The following is a description of a gene set: Genes up-regulated in T98G cells (glioblastoma) by TNC. Human Gene Set: RUIZ_TNC_TARGETS_UP species: Homo sapiens Tenascin-C is an adhesion-modulating extracellular matrix molecule that is highly expressed in tumor stroma and stimulates tumor cell proliferation. Adhesion of T98G glioblastoma cells to a fibronectin substratum is inhibited by tenascin-C. To address the mechanism of action, we performed a RNA expression analysis of T89G cells grown in the presence or absence of tenascin-C and found that tenascin-C down-regulates tropomyosin-1. Upon overexpression of tropomyosin-1, cell spreading on a fibronectin/tenascin-C substratum was restored, indicating that tenascin-C destabilizes actin stress fibers through down-regulation of tropomyosin-1. Tenascin-C also increased the expression of the endothelin receptor type A and stimulated the corresponding mitogen-activated protein kinase signaling pathway, which triggers extracellular signal-regulated kinase 1/2 phosphorylation and c-Fos expression. Tenascin-C additionally caused down-regulation of the Wnt inhibitor Dickkopf 1. In consequence, Wnt signaling was enhanced through stabilization of beta-catenin and stimulated the expression of the beta-catenin target Id2. Finally, our in vivo data derived from astrocytoma tissue arrays link increased tenascin-C and Id2 expression with high malignancy. Because increased endothelin and Wnt signaling, as well as reduced tropomyosin-1 expression, are closely linked to transformation and tumorigenesis, we suggest that tenascin-C specifically modulates these signaling pathways to enhance proliferation of glioma cells. from publication Ruiz C, Huang W, Hegi ME, Lange K, Hamou MF, Fluri E, Oakeley EJ, Chiquet-Ehrismann R, Orend G (PMID 15492259), and this is the list of marker genes: SSBP2, LEF1, SIDT2, LRIG1, BNIP3L, GDF15, MEIS1, SELENOP, TRIB2, ROBO1, TCF12, PTPN13, RARRES1, C1RL, PLK2, YPEL5, SLC2A3, SNCAIP, TPP1, SPP1, BAZ2B, COL3A1, CDH11, BTG1, GSN, ZBTB20, COL4A5, CTSC, SAT1, MAGED4B, DDIT4, TBC1D3F, ST3GAL1, HERPUD1, COL18A1, KLF9, TRO, CXCL12, ID2, PHF21A, SEMA3C, EXTL2, FLRT2, LTA4H, BAMBI, SEMA5A, IFIH1, AUH, HNMT, CLU, GBP2, HEY1, GLCE, PSAP, PLAAT4, LTBP3, PDCD4, ZCCHC24, TMT1A, NR2F1, ARHGAP28, BTN3A3, CBLB, SLC16A4, IQGAP2 (IQ motif containing GTPase activating protein 2), ACSL4, SCG2, FOXF1, FCGRT (NCBI Gene Id 2217), MAN1A1, TM4SF1, KCTD12, ALDH3A1, RAB17, COL5A2, TIMP4, TNKS, ZNF532 (NCBI Gene Id 55205), WIPI1, KLHL24, ARID5B, APOE, PDGFRA, NBR1, GRN, VGLL4 (vestigial like family member 4), ANXA4, SPTSSA, CSGALNACT1, LDB2, TNFSF10, PLPP1, C21orf91, PNRC1, TDO2, GOLGB1, HBP1, RESF1, SOX4, IMPA2, ATP2B4, TBL1XR1, C14orf132, PCMTD2, BDH2, SNAP25, ITSN1, SLC23A2, WDR26 (WD repeat domain 26), UBXN4, MAFB, FAM110B, NAP1L1 (NCBI Gene Id 64165), SELENBP1, ENPP2, VCAM1, HPGD, COL1A2, WSB1, CAT, IL1R1, OLFML2B, WASHC2C, STON1, PDGFRB, CTSA (cathepsin A), SLC6A15, GPRC5C, BTN3A2 (NCBI Gene Id 11118), PDE5A, GBE1, KDM5B, CLCA2, SLC5A3, EDNRA, EYA1, JCAD, TBXAS1, BCL6, CHST15, SLC35E2B, FOXF2, KRIT1, MAGED1, RCBTB1 (NCBI Gene Id 55213), ATP9A, IGFBP7, NUMA1, EAPP, A2M, ARRB1, SLC2A10, RSRP1, PROS1, MARCHF6, CTDSP2